The following is a description of a gene set: Genes predicted to be targets of miRBase v22 microRNA mmu_miR_7669_5p in miRDB v6.0 with MirTarget v4 prediction scores > 80 (high confidence targets). from publication Chen Y, Wang X (PMID 31504780) Mouse Gene Set: MIR_7669_5P studied in species Mus musculus, and this is the list of marker genes: Fbxo33, Smarca5, Med17, Agr3, Ube2j1, Phyh, Rmnd5a, Znhit6, Bmf, Egln3, Gpatch2l, Slc7a1, Dnajc1, Sh2b1, Ube2h, Wasf1, Btnl2, Pnma2, Higd1a, Psg16, Glrx2, Zdhhc17, Zbtb24, Pcnp, Fndc5, Prkg1, Rmdn3, Bivm, Adamts6, Pcdhb20, Amigo3, Rasa2, Gm14295, Robo1 (NCBI Gene Id 436378), Ptpn9, Fnip1, Kat2b, Snx18, Txndc5, Nova1 (NCBI Gene Id 664883), Zbtb10, Asz1, Bcl9, Depdc5, Cntn6, Clmn (calmin), Mcf2l, Pcdh7, Tal1, Smarca2, Lnpk, Bicd2, Aars2, Lsm6, C3ar1, Txlng, D030056L22Rik, Pag1, Anks1